The following is a description of a gene set: species: Homo sapiens Hand muscle atrophy Human Gene Set: HP_HAND_MUSCLE_ATROPHY Muscular atrophy involving the muscles of the hand., and this is the list of marker genes: PRX, FLNC, PMP22, GBF1, DCTN1, SCO2, SPTLC1, ADAMTS15 (NCBI Gene Id 219807), SLC52A3, TIMM8A, BSCL2, HSPB3, TIA1, PDK3, CHCHD10, RYR1, SLC39A13, LMNA, ALS2, TFG, MPV17, TRPV4, VCP, FXN, MORC2, CAV3, MARS1, GARS1, NEB, PLOD3, DYSF, KLHL9, HARS1, GDAP1, LDB3, COMP, CHRNA1, ITPR3, SLC5A6, SQSTM1, SLC12A6, REEP1, NGLY1, SLC25A21, ACTA1, SPG11, UBAP2L, HINT1, KIF1A, TRIM2, KANSL1, JAG1, NEFL, IDUA, SVBP, MPZ